The following is a description of a gene set: Phospholipase C-mediated cascade; FGFR4 species: Mus musculus Mouse Gene Set: REACTOME_PHOSPHOLIPASE_C_MEDIATED_CASCADE_FGFR4, and this is the list of marker genes: Plcg1, Fgf15, Fgf6, Fgf2, Fgf8, Klb, Fgf18, Fgfr4, Fgf4, Fgf16, Fgf20, Fgf23, Fgf9, Fgf1, Fgf17